The following is a description of a gene set: species: Mus musculus Any process involved in the maturation of a precursor Small SubUnit (SSU) ribosomal RNA (rRNA) molecule into a mature SSU-rRNA molecule from the pre-rRNA molecule originally produced as a tricistronic rRNA transcript that contains the Small Subunit (SSU) rRNA, 5.8S rRNA, and the Large Subunit (LSU) in that order from 5' to 3' along the primary transcript. Mouse Gene Set: GOBP_MATURATION_OF_SSU_RRNA_FROM_TRICISTRONIC_RRNA_TRANSCRIPT_SSU_RRNA_5_8S_RRNA_LSU_RRNA, and this is the list of marker genes: Wdr46, Tbl3, Rrp36, Slx9, Tsr1 (TSR1 20S rRNA accumulation), Rps19, Rpp40, Dcaf13, Ercc2, Utp4, Utp6, Bms1, Utp25, Nop9, Heatr1, Nol10, Kri1, Dhx37, Fcf1 (FCF1 rRNA processing protein), Rps21, Rps16, Rcl1, Ngdn, Utp23, Pwp2, Utp3, Gtf2h5, Abt1, Bysl, Wdr43, Rps8 (ribosomal protein S8, NCBI Gene Id 20116), Tsr2, Rrs1